Given this list of marker genes COL1A2, FGFR3, COL2A1, SLC26A2, GLI1, DYNC2LI1, RMRP, PTH1R, COL1A1, PRKACB, SOX9, EVC, EVC2, PRKACA, here is a description of the gene set: Human Gene Set: HP_NEONATAL_SHORT_LIMB_SHORT_STATURE Neonatal short-limb short stature A type of short-limbed dwarfism that is manifest beginning in the neonatal period. species: Homo sapiens